The following is a description of a gene set: from publication Szanto A, Balint BL, Nagy ZS, Barta E, Dezso B, Pap A, Szeles L, Poliska S, Oros M, Evans RM, Barak Y, Schwabe J, Nagy L (PMID 21093321) Human Gene Set: GSE16385_MONOCYTE_VS_MACROPHAGE_UP Genes up-regulated in monocytes versus macrophages. Human CD14 positive monocytes were purified from healthy volunteers’ blood and cultured in vitro for 4, 12, 24, 72 hours. While culturing, macrophages were activated alternatively with interleukin-4 (IL-4 100 ng/ml) or classically with interferon-gamma (IFNg 100 ng/ml)+tumor necrosis factor (TNF 50 ng/ml) or left without activation. Simultaneously, macrophages were also treated with vehicle (DMSO:ethanol) or 1mM synthetic PPARg agonist, Rosiglitazone. We used Affymetrix microarrays (U133Plus 2.0) to analyze activation and PPARg-induced gene expression changes. species: Homo sapiens, and this is the list of marker genes: WDFY1 (WD repeat and FYVE domain containing 1), KLHL12, NEIL3, CFAP68, CCNE1, SRRM4, RPL3L, SORCS2, GALNT6, ROS1, UTP15, RCC1, SKP1, TPGS2, SOD2, WEE2, ANAPC16, LARS2, FABP7, ELK4, RRP1B, NIPSNAP2, STK11IP, NSUN4, CYSTM1, TMEM167B, TOMM6, PDF, ZNF414, DUSP19, RAMP3, LMLN, IGSF23, NNT, PDCD2, CRADD, DSTYK, RGS10, EXOC6, SLC2A6, TDRD1, SMIM19, SRP54, DELE1, RANBP17, AIM2, GMPPA, HLA-DOA, TNFRSF11B, SYNJ2, SAMHD1 (NCBI Gene Id 25939), USP10, LFNG, ISCU, RDH10, TWNK, SAR1B, DPH1, ZNF212, CTSB, EHD3, SPC25, TPRG1L, ZCCHC12, CDKL1, TMEM71, KATNB1, LRRC15, LARGE1, NUDT7, SMCO4, FBXO2, CAMK2B, CREB3L1, FTO (NCBI Gene Id 79068), SGIP1, NAB2 (NCBI Gene Id 4665), MECR, ZNF354C, GM2A, SPATA3, CPXM1, CCDC172, ENOX2, SHOC2, CYLC1, OCIAD1, ICOS, FHIT, ENC1, SMAD7, EI24, NINJ2, PUM3, C1QTNF12, ZBTB3, ESR2, NOVA1, BCL7B, PABPC4, FAM50A, CD53, KIAA1143, DYNC2I2, CMPK1, PDIA4, NCOA7, CRTAC1, MORF4L2, CPNE5, MOG, NCKAP1L, TNNI3, AFF2, SH3BGRL, CALML4, GPCPD1, FAM241B, TMUB2, FGF3 (NCBI Gene Id 2248), HINT3, TREX1, SAPCD1, ZNF679, PADI6, UCMA, USB1, SLC35D1, NCOA4, CLDN14, ASPA, IL13RA2, EQTN, YPEL4, DNAJC3, PPP2R2D, RSPH6A, RDH12, ZC3H12C, CSN2, TSACC, MAT2B, LYRM4, GJC2, PLEKHH2, PSMB3, GLIPR1, PGAP3, CHURC1, FBXO46, CD248, CAPS2, ENDOV, BEX2 (brain expressed X-linked 2), PRELID3B, SYTL3, NDRG3, CNIH2, SRR, KLHL11, TANGO6, TIE1, AFAP1L1, DCTN4, SERTAD4, PEF1, GPRC5B, PSEN2, MPZL2, GPS1, STAR, ARL2BP, OTULINL, NDUFS2, ARSJ, NMI, TCEAL1, GPT2, FCGRT, MRTO4, DZIP1, BFSP1, AVEN, YIPF3, C16orf92, SLC7A5, GPR180, STAP1, EIF3E, SH3BP5, ZNRD2, GNGT2, BACH2 (BTB domain and CNC homolog 2), APOA4, ACTR3B, UQCC3, CPNE4, SOX1, SRBD1, CREBL2